Given this list of marker genes HMGB1, ST6GALNAC4, ST3GAL4, STOM, TNF, MGAT1, PCBP1, TOP2B, SLC6A19, GYPA (glycophorin A (MNS blood group)), TMEM41B, ITGB5, EGFR, DAG1, IGF2R, JUN, CDHR3, CXADR, MYH10, DPP4, RSF1, PTBP1, PTX3, LRRC15, TARBP2, MRC1 (mannose receptor C-type 1), ZDHHC20, SLC3A2, HTR2A, TRIM13, TFAP4, CTSB, MBL2, RAB7A, CANX, ITGA2, DDX6, DDX3X, PARP16, WWP2, SLC10A1, WWP1, CXCR6, AGTR1, RAB1A, ARL8B, MYH9, IFIT5, IFI16, VPS28, LAMP3, APOBEC3C, PLSCR1, TSG101, AVP, MAVS, NEDD4, PIK3C3, IFNL3, TRIM6, CHMP5 (charged multivesicular body protein 5), VPS37C, TRIM62, CHMP1B (charged multivesicular body protein 1B), PPIA, ISG20, EFNB3, KPNA2, GAS6, SMPD1, UBP1, MGAT4C, OAZ2 (NCBI Gene Id 4947), SLC52A2, MGAT4B, MGAT2, MAN2A1, LARP7, CSF1R, TRIM14, RAD23A, HCFC1, SRPK2, HPN, PIKFYVE, MAN1B1, OAS2, DHX9, OAS3, CHMP2A, ATP7B, HYAL2, MIR222, CHMP4BP1, CR1, RRP1B, APOBEC3F, NFIA, APOBEC3G, TMPRSS4, TOP2A, PSMC3, ITGA5, MOGS, CHMP7, SIVA1, CHMP6, ST3GAL1, ZNF502, XPR1, IFITM1, VPS37D, CALCOCO2, ZNFX1, CHMP1A, MX1, SLC52A1, ST6GALNAC2, TRIM25 (NCBI Gene Id 7706), SRC, EDEM2, TRIM31, GTF2B, IRF7 (NCBI Gene Id 3665), TYRO3, CSNK1A1, HEXIM1, CDK1, LDLR, ZBED1, SLC20A2, ANPEP (alanyl aminopeptidase, membrane), SMARCB1, NUCKS1 (NCBI Gene Id 64710), TMEM39A (transmembrane protein 39A), HSPA1B, MIR221, GRK2, FMR1, CHMP4A, CREB3, AXL, TPCN2, INSR, TFRC, CCL5, CAV1, OAS1, PPIB, PRKN, CD81, TP53, LGALS9, CLEC4G, VPS4B, NPC1, GALNT1, NR5A2, PARD6A, EIF2D, F11R, APCS, ATG5, IFI27, SPCS3, CXCL8, CCR5, PPID, MID2, BSG, NECTIN2, CLEC5A, IFIT1, ST6GAL1, LEF1, VPS37A, USF1, GSK3A, GSK3B (NCBI Gene Id 2932), APOBEC3H, RNASEK, PROX1, ST6GALNAC3, SNW1, FKBP6, USF2, CCL1, APOBEC3D, HMGA2, USP6NL, TARDBP, YTHDC2, IFNB1, ZFP36, ATG12, PDE12, HSP90AB1, CLDN9, SERPINB3, RPSA, SCARB1, CD74, CSNK2B, LTF, SCARB2, CCL8, PPIH, TRIM32, MGAT5, CLDN6, HLA-DRB1, ITGB1, CD209, EEF1A1, RAB43, NOTCH1, DDB1, CR2, SMARCA4, STAU1, RSAD2, SLC7A1, BCL2, PDCD6IP, APOBEC3A, SLC1A5, TRIM5, TRIM28, CCNT2, GPR15, CTDP1, LAMTOR5, MVB12A, IDE, TNFRSF4, DEK, LAMP1, SMC5, NMT2, CTSL, PEG10, NUP153 (nucleoporin 153), SRPK1, BST2, CDK9, FURIN, EIF2AK4, TNIP1, PKN2 (protein kinase N2), OAZ3, VPS37B, ACE2, OAZ1, LARP1, IFIH1, LGALS1, PCSK5, ITGAV, EIF3L, APOE, CHMP2B, SHFL, HDAC1, CNOT7, ILF3, SIGLEC1, PVR, CD55, ZC3HAV1, EPS15, SLAMF1, TRIM21, CH25H, ZDHHC9, CCL2, VAMP8, MCTS1, NECTIN3, SELPLG, FUT8, APOBEC3B, ITCH, CCL4, ZC3H12A, EIF3F, PPIE, ADARB1, RAN, BANF1, PC, CTBP1, TRIM8, CAV2, NRP1, ARK2N, CCNK, KPNA3, UVRAG, PCBP2, RCC1, MOG, NECTIN1, AVPR1B, FBXL2, EFNB2, ISG15, EIF2AK2, TMPRSS2, KPNA6, CTBP2, PAIP1, CXCR4, HS3ST5, ST3GAL3, STAT1, IFITM2, TRIM27, EPHA2, VAPB, HCFC2, CD46, NECTIN4, CFL1, TNFRSF14, ITGB6, ZDHHC8, DDX5, VPS4A, ZNF639, TMEM250, ZFYVE1, VCP, CD28, BTBD17, SLC38A8, P4HB, PABPC1, IL32, CD4, N4BP1, SLPI, TRIM38, TAF11, EIF3B, NCAM1, VPS18, TRIM15, MDFIC (NCBI Gene Id 29969), RAB1B, JPT2, CHMP4C, CCNT1, FAM111A, EP300, CD80, ADAR, CCL3, CBL, SP100, CSDE1, MITD1, SPCS1, HAVCR1, LIG4, INPP5K, CLEC4M, CHMP4B, OASL, REST, MGAT4A, PARP10, ICAM1, VAPA, GBP7, TBC1D20, KIAA0319L, CHMP3, TPCN1, SSB, EIF3A, EIF3G, IFITM3, CD86, AICDA, DYNLT1, HSPA1A, PARP9, SMC6, ST3GAL2, TRIM11, SP1, HACD3, LRSAM1, CLDN1, BICD1, EIF3D, ATG16L2, POU2F3, MVB12B, ATG16L1, ITGB7, ITGB3, PRMT1, PHB1, RNASEL, BRD4, DDX56, MON1B, DENR, CHD1, here is a description of the gene set: Human Gene Set: GOBP_VIRAL_PROCESS species: Homo sapiens A multi-organism process in which a virus is a participant. The other participant is the host. Includes infection of a host cell, replication of the viral genome, and assembly of progeny virus particles. In some cases the viral genetic material may integrate into the host genome and only subsequently, under particular circumstances, 'complete' its life cycle.